The following is a description of a gene set: Human Gene Set: HP_ABNORMAL_NEURAL_TUBE_MORPHOLOGY Any structural anomaly of the hollow epithelial tube found on the dorsal side of the vertebrate embryo that develops into the central nervous system (i.e. brain and spinal cord). Abnormal neural tube morphology studied in species Homo sapiens, and this is the list of marker genes: ARID1B, PIK3CA, PLCH1, FKTN, STAG2, SUFU, LIMK1, INPP5E, TMEM67, UBA2, TOGARAM1 (NCBI Gene Id 23116), GRIP1, PTPN11 (NCBI Gene Id 84990), DLL3, CRB1, LIG4, NCF1, GAS1, RUNX2, SF3B2, RPGRIP1, TBX1, GTF2IRD1 (GTF2I repeat domain containing 1), RAF1, FOXI3, FANCB, MEG3, C2CD3 (NCBI Gene Id 26005), TRIM36, ITGB4, FILIP1, AIPL1, KATNIP, BUD23, RECQL4, EIF4H, POMT1, XRCC2, ATP6V1B2, FUZ, PDE6D, LARGE1, EXT2, FRAS1, TMEM270, EOGT, SHH, GDF6, KIF22, DLL4, RASA1, LMX1B, PUF60, NF2, FGF8, GTF2I, SIN3A, MEOX1 (NCBI Gene Id 4222), TXNDC15, RPGRIP1L, LAMB1, TUBB4B, AMER1, FOXH1, SLX4, KIF7, BRCA2, MAD2L2, GALNS, LCA5, ARL13B, CDH1, BTD, NAXE, UBE2T, ARPC4, CEP290, OFD1, PALB2, MAFB, B9D1, ARHGAP31, FLNA, RBPJ, SLC25A19, DACT1, CSPP1, CCNQ, KCNJ13, CEP104, FANCE (NCBI Gene Id 2178), USP45, RXYLT1, GPKOW, KIAA0753, CHN1, POLR1B, SLC26A2, HES7, KCNQ1OT1, NEK9, IRF6, RFC2, FKBP6, FANCG, MTR, CREBBP, SPATA7, ACTB, COLEC11, FANCF, FANCL, B3GLCT, COLEC10, FGFR3, SALL4, BMS1 (NCBI Gene Id 9790), SOX9, VANGL1, VPS37D, ESCO2, B4GAT1, RFWD3, CCL2, CEP55, SIX3, ARMC9, STX1A, DLK1, HOXD13, FANCI, PSAT1, TGIF1, CRX (NCBI Gene Id 1406), POLR1D, ESAM, NOTCH3, SETBP1, ALG3, GMPPB, HSPG2, EBF3, DNAJC30, BMP2, DKK1, RAD51, CLIP2, MTHFD1, CHRNG, RAB23, SMC1A, METTL27, HIRA (histone cell cycle regulator), MTRR, IKBKG, PTDSS1, STIL, PAX3, BRAF, MYH3, EXT1, CDON, JMJD1C, CRIPTO, GP1BB, POLA1, RBM8A, COMT, TCTN2 (NCBI Gene Id 79867), LRAT (NCBI Gene Id 9227, lecithin retinol acyltransferase), GNPTAB, IMPDH1, CCBE1, H19, HMX1, SEC24C, ZNF423, WNT7A, FANCM, POMK, B9D2, CBY1, HAAO, MAP3K7, CPLANE1, MASP1, UFD1, TBL2, PIBF1, POLR1C, TCTN3, SC5D, AHI1, IQCB1, TBXT, SNRPB, VSX1, ZIC1, FKRP, PCYT1A, CEP120, NSUN2, TMEM216, FGFR1, SRRM2, ARSB, DARS1, IFT74, HNRNPK, ELN, TMEM218, FANCC, SMO, EFEMP2, ALX1, BICD2, ARL3, BAZ1B, NDE1, POMGNT1, CYP27A1, RIPPLY2, KIAA0586, PLEC, RREB1, ABCD1, KCNH1, FANCD2, ZSWIM6, GLI2, TCOF1, GTF2IRD2, MTHFR, NODAL, RPE65, NF1, HRAS, FREM2, FLI1, ALX4, CRPPA, TBX6 (T-box transcription factor 6), COL2A1, MKS1, IFT140, BRCA1, CUL7, TMTC3, DISP1, PTCH1 (patched 1), TMEM237, FANCA, ZIC3, RDH12, CYP26B1, DRG1, FLVCR2, NMNAT1, TMEM231, GUCY2D, ARVCF, FIBP, POMT2, NOTCH2NLC, TCTN1, FLNB, GDF3, TMEM107, RTL1, MESP2, PORCN, PAK2, ZIC2, RAD51C, TBC1D24 (TBC1 domain family member 24), LFNG, NOTCH1, RORA, SCAF4, TBX15, KANSL1 (NCBI Gene Id 791085), NUAK2, GLB1, BRIP1, MSX2, ERCC4, B3GALNT2, PHGDH, CDK13, DOCK6, WDR81, HYLS1, TULP1, EP300 (NCBI Gene Id 2033), CEP41, GJA1 (gap junction protein alpha 1), RMRP, RD3 (RD3 regulator of GUCY2D), VANGL2, DLL1, SUPT16H, TMEM138, ALX3, BMPER (BMP binding endothelial regulator, NCBI Gene Id 168667), TNXB, NPHP1, COL18A1, CC2D2A, WBP11, IGF2, RPS19, GLI3